Given this list of marker genes NAGLU, MATN3, TMEM270, GDF5 (growth differentiation factor 5), SUZ12, VAPB, ANKH, VANGL1, FKBP6, PRRT2, GNPTG, VPS33A, NCF1, AGA, ANTXR2, IDH2, PLOD2, PTF1A, CISD2, IQSEC2, GPHN (gephyrin), POMT1, FBN1, NFKBIL1, SLC26A2, AKT1, FLII, ANKRD55, NAE1, COL2A1, SYNE2, TBX5, ATRX, SETBP1, METTL27, RAI1, SGSH, SMC1A (structural maintenance of chromosomes 1A), GTF2IRD1, TAF6, TRPV4, NOG, GNS, DNAJC30, STING1, ALDH3A2, KRT83, ACTG2, SUMF1, INPPL1, TPM2, ADAMTS2, RAD21, NDE1, TBX3, ADAMTSL4, HFE, MACROH2A1, PDPN, RAB3GAP2, PTPN2, FGFR3, PITX1, LSS, HDAC8, MMP23B, EZH2, PNKD, NEK9, SALL4, MFN2, CASZ1, GTPBP2, HPGD, RAB3GAP1, TNNT3, BUD23, ASPN (NCBI Gene Id 54829), GNPTAB, CBS, CCN6, ERCC6, ARSB, MMP13, OCRL (NCBI Gene Id 4952), PAX3, ACTG1, TBL2, PRKCZ, RAB18, SF3B4, MTX2, MYH3, PTH1R, NALCN, EMG1, MYBPC1, IL10, CHMP1A, ADAMTS10, SPEN, HLA-B, TBC1D20, FHL1, RFC2, TNNI2 (troponin I2, fast skeletal type), ERCC2, COMP, ADAMTS17, COL1A2, ACTB (NCBI Gene Id 60), BAZ1B, RNU4ATAC, ELN (elastin), DKK1, CLIP2, LIMK1, IDH1, NSD1, EMD, LMNA, SKI, LTBP3 (NCBI Gene Id 4054, latent transforming growth factor beta binding protein 3), FLNA, BANF1, ERCC5, HSPG2, SYNE1, HGSNAT, VPS37D, LEMD3, COL1A1, ASPA, IL2RB, TMEM43, WFS1, LUZP1, NPR2, SLC6A5, UBE4B, GLB1, DEAF1 (DEAF1 transcription factor), PTPN22, EIF4H, PIEZO2, BRD4, FUZ, STAT4, GLRB, GTF2I, PCYT1A, SH3PXD2B, IDUA, TGDS, TNFRSF11B, MMP9, PLA2G6, ADAMTSL2, UBAP2L, FBN2, IRF6, RECQL4, P4HA2, TRAPPC2, L1CAM, WRN, ATAD1, PPP1R12A, GTF2IRD2, CD244, RERE, IL2RA, CHST11, SLC22A4, BMP6, BMPR1B, GUSB, CD247, SMC3, HLA-DRB1, SCUBE3, MECP2, KCNAB2 (potassium voltage-gated channel subfamily A regulatory beta subunit 2), ZMPSTE24, PRDM16, USB1, EPG5, FGF9, STX1A, FKBP10, ERCC1, PRG4, GABRD, NDUFS3, GLRA1, MAN2B1, LTBP2, CIITA, SMAD4, HGD, SHOX, NIPBL, here is a description of the gene set: Joint stiffness is a perceived sensation of tightness in a joint or joints when attempting to move them after a period of inactivity. Joint stiffness typically subsides over time. Human Gene Set: HP_JOINT_STIFFNESS species: Homo sapiens Joint stiffness